Given this list of marker genes Crebbp, Flvcr1, Col1a1, Crispld1, Rras, Twist2, Tgfb3, Dkk1, Ski, Lrp6, Ankrd11, Scx, Ptpn11, Lef1, Asph, Kat6a, Zfp640, Tbx1, Mmp2, Ssbp3, Pdgfra, Sgpl1 (sphingosine phosphate lyase 1), Cdk2ap1, Msx1 (msh homeobox 1), Tfap2a, Nog, Arid5b, Wnt3, Tgfb1, Zfp950, Vps13b, Dlx5, Tiparp, Pax9, Nipbl, Atp6ap2, Specc1l, Ihh, Csrnp1, Ep300, Plekha1, Prickle1, Crispld2, Braf, Tgfb2 (transforming growth factor, beta 2), Tcf7l2, Schip1, Rab3gap1, Stra6, here is a description of the gene set: Mouse Gene Set: GOBP_HEAD_MORPHOGENESIS The process in which the anatomical structures of the head are generated and organized. The head is the anterior-most division of the body. studied in species Mus musculus